The following is a description of a gene set: Human Gene Set: GOCC_ESCRT_COMPLEX An endosomal sorting complex involved in membrane fission processes related to sorting of multivesicular bodies (MVB) in the endocytic pathway, cytokinesis and viral budding among other processes. studied in species Homo sapiens, and this is the list of marker genes: STAM2, CHMP3, CHMP1B, CHMP4BP1, DIAPH3, CHMP4A, VPS37B (NCBI Gene Id 79720), VPS37C, CHMP1A, VPS28, UBAP1, CHMP5, TSG101, VPS25, HGS, CHMP7, CHMP2A, SNF8, UBAP1L, VPS37D, CHMP4C, UEVLD, STAM, CHMP2B, CHMP4B, MVB12B, VPS37A, MVB12A, VPS36, CHMP6